The following is a description of a gene set: Any process that increases the rate or frequency of muscle cell apoptotic process, a form of programmed cell death induced by external or internal signals that trigger the activity of proteolytic caspases whose actions dismantle a muscle cell and result in its death. Human Gene Set: GOBP_POSITIVE_REGULATION_OF_MUSCLE_CELL_APOPTOTIC_PROCESS species: Homo sapiens, and this is the list of marker genes: SOD2, IL12A, MIR320A, MIR16-1, MIR28, MIR195, CAPN2, TIGAR, IL12B, PDCD4, ATF4, MIR17 (NCBI Gene Id 406952), ATP2A2, CAMK2D, MIR24-1, PTPN1, MIR140, FOXO1, RBM10, E2F3, CAMK2A, TP53 (NCBI Gene Id 7157), SMAD4, MIR1-1, MIR34A, MFN2, STUB1, LTK, MAP3K5, IFNG, PPARG, BAG1, CDKN2A, BNIP3, ADCY10